The following is a description of a gene set: species: Homo sapiens Human Gene Set: GOMF_HEPARIN_BINDING Binding to heparin, a member of a group of glycosaminoglycans found mainly as an intracellular component of mast cells and which consist predominantly of alternating alpha-(1->4)-linked D-galactose and N-acetyl-D-glucosamine-6-sulfate residues., and this is the list of marker genes: LIPC, FURIN, FGF9, PRELP, APOA5, FGF4, ADAMTS15, CCL15, VEGFB, SERPINE2, SERPINC1, LRPAP1, SERPINA5, ZNF207, IMPG1, ADAMTS3, CTSG (NCBI Gene Id 1511), LAMC2, CCN3, PTCH1, SFRP1, FGFBP3, CXCL13, FGFR4, NRP1 (neuropilin 1), RSPO2, COL25A1, ECM2 (NCBI Gene Id 1842), ADAMTSL5, COLQ, MDK, PTPRC (protein tyrosine phosphatase receptor type C), RSPO4, ELANE, CCDC80, PCOLCE, APP, RTN4R, HRG, IMPG2, TGFBR3, VEGFA, PTPRF, APOB, LTBP2, CCN6, REG4, RSPO3, COL5A1, PLA2G2D, EFEMP2, LIPI, LGR6, TWSG1, DEFB106A, PF4, FSTL1, CXCL6 (C-X-C motif chemokine ligand 6, NCBI Gene Id 6372), SMOC1, PDCD5, HSD17B12, PTPRS, CXCL8, CXCL10, ANG, CCN4 (cellular communication network factor 4), COL13A1, CLEC3B (C-type lectin domain family 3 member B), BSPH1, MSTN, NRP2, APLP2, GREM2, PRG2, CCL23, COL11A1, APLP1 (NCBI Gene Id 333), ALK, CRISPLD2, TENM1, FBN1, FGFRL1, FGFBP1, LTF, SMOC2 (SPARC related modular calcium binding 2), FBLN7, SLIT3 (slit guidance ligand 3), APOE, KNG1, ADGRG1, SLIT2, THBS1, RTN4RL1, F2, SOD3 (NCBI Gene Id 6649), ADAMTS1, LIPH, NAV2, SAA1, PF4V1, CCN5, PTN (NCBI Gene Id 5764), AAMP, LPL, RPL22, NELL1, LIPG, SELL, LPA, FGFR2, ZNF146, FGF1, ADA2, PCOLCE2, ADAMTS5, SOST, FGF14, CFH, DEFB106B, FGF7, COL5A3, NELL2, PAFAH1B1, HBEGF, FGF10, BMP4, ELSPBP1, FN1 (NCBI Gene Id 2335), SLIT1, PCSK6, COMP, PRSS57, CCN2, PGF, RSPO1, CXCL11, COL23A1, SELP, POSTN, CEL, TMEM184A, MPO, THBS4 (thrombospondin 4), FGFR1, ANOS1, APOH (NCBI Gene Id 350), ANGPTL3, RPL29, COL28A1, TNXB, LXN, ADAMTS8, CCN1, EVA1C, F11, FGF12, VTN, NDNF, THBS2, AOC1, HDGF, THBS3, SERPIND1, MPIG6B, CCL7, GPNMB, H1-1, AZU1, FGF2, CCL8, BMP7, SERPINA10